The following is a description of a gene set: Human Gene Set: WP_OVERLAP_BETWEEN_SIGNAL_TRANSDUCTION_PATHWAYS_CONTRIBUTING_TO_LMNA_LAMINOPATHIES studied in species Homo sapiens Overlap between signal transduction pathways contributing to LMNA laminopathies, and this is the list of marker genes: TCF7, CTSK, CEBPA, E2F1, DICER1, ZMPSTE24, TGFB2, ICMT, APC, GSK3B, RUNX2, WNT7B, TGFB1, PPARG, TLE1, NOTCH1, FNTA, MYOD1, TCF7L1, CDK4 (cyclin dependent kinase 4), CDKN1A, SPP1, CREBBP, WNT10B, SREBF1, LEF1, MSTN, AGO2, MAOA, AXIN1, CEBPD, HES1, HDAC1, HMGA2, TMPO, HES5, TARBP2, JUNB, CEBPB, MIRLET7B, RB1, KAT2B, LEMD3, EMD, MIR33B, TNFRSF11B, SMAD2, NAP1L1 (nucleosome assembly protein 1 like 1), TCF7L2, CTNNB1, SMAD3, CSNK1A1, LMNA, CSNK1A1L, BMP2, MAOB, ACTB